The following is a description of a gene set: Angiogenesis is regarded as essential for tumour growth. However, we have demonstrated that some other aggressive non-small-cell lung carcinomas (n-SCLC) do not have angiogenesis. In this study, using cDNA microarray analysis, we demonstrate that angiogenic and nonangiogenic tumour types can be distinguished by their gene expression profiles. Tissue samples from 42 n-SCLC patients were obtained with consent. In all, 12 tumours were nonangiogenic and 30 angiogenic. The two groups were matched by age, sex, smoking and tumour stage. Total RNAs were extracted followed by microarray hybridization and image scan procedure. Data were analysed using GeneSpring 5.1 software. A total of genes were found to be able to separate angiogenic from nonangiogenic tumours. Nonangiogenic tumours have higher levels of genes concerned with mitochondrial metabolism, mRNA transcription, protein synthesis and the cell cycle. Angiogenic tumours have higher levels of genes coding for membrane vesicles, integrins, remodelling, angiogenesis and apoptosis. These results further support our first finding that nonangiogenic lung tumours are fast-growing tumours filling the alveoli in the absence of vascular remodelling. We raise the hypothesis that in nonangiogenic tumours, hypoxia leads to a higher activation of the mitochondrial respiratory chain, which allows tumour growth without triggering angiogenesis. Down-regulated genes that separate angiogenic from non-angiogenic non-small cell lung carcinoma (NSCLC) samples. from publication Hu J, Bianchi F, Ferguson M, Cesario A, Margaritora S, Granone P, Goldstraw P, Tetlow M, Ratcliffe C, Nicholson AG, Harris A, Gatter K, Pezzella F (PMID 15592519) Human Gene Set: HU_ANGIOGENESIS_DN species: Homo sapiens, and this is the list of marker genes: H2AZ1, DARS1, MDH1, ZNF217, GCDH, GPI, ANXA7, NDUFB6, MCM6, EIF3M, RPA3, LONP1, GMPS, ITM2A, PFN2, GNAI1 (G protein subunit alpha i1), H2AZ2, VAPA, ATP5PO, ATP6V1G1, RBMXL2, POLR2K, SOD1, HNRNPA2B1, PTP4A2, HMGN4, PSMB1, SMYD2, HMGN1, SET, GTF2A2, CKS2, CDK2AP1, PDS5A, DHX15, PLXNA2, GSC2